The following is a description of a gene set: Genes positively correlated with antibody response in blood in adults (18-40) after exposure to Sanofi Pasteur, SA, Inactivated influenza vaccine, time point 0D from publication Franco LM, Bucasas KL, Wells JM, Niño D, Wang X, Zapata GE, Arden N, Renwick A, Yu P, Quarles JM, Bray MS, Couch RB, Belmont JW, Shaw CA (PMID 23878721) Identification of the host genetic factors that contribute to variation in vaccine responsiveness may uncover important mechanisms affecting vaccine efficacy. We carried out an integrative, longitudinal study combining genetic, transcriptional, and immunologic data in humans given seasonal influenza vaccine. We identified genes exhibiting a transcriptional response to vaccination, significant genotype effects on gene expression, and correlation between the transcriptional and antibody responses. The results show that variation at the level of genes involved in membrane trafficking and antigen processing significantly influences the human response to influenza vaccination. More broadly, we demonstrate that an integrative study design is an efficient alternative to existing methods for the identification of genes involved in complex traits. DOI:http://dx.doi.org/10.7554/eLife.00299.001. studied in species Homo sapiens Human Gene Set: FRANCO_BLOOD_SANOFI_PASTEUR_SA_INACTIVATED_INFLUENZA_VACCINE_CORRELATED_WITH_ANTIBODY_RESPONSE_AGE_18_40YO_0DY_POSITIVE, and this is the list of marker genes: SNRNP25, LYRM4, GABBR1, MED22, MIR600HG, SUSD3, AHSA2P, SAT2, KCNG1, TCL1A, DHX35, PAOX, FCRLA, PIBF1, GCNA, BLK, BST2, UBE2Z, LMTK3, RINL, LTB, CD79B